Given this list of marker genes DEFA3, CD4, DEFA1, PRSS2 (serine protease 2), ART1 (ADP-ribosyltransferase 1), DEFA6, env, DEFA4, DEFA5, PRSS3, here is a description of the gene set: Humans have 7 alpha defensin genes plus 5 pseudogenes (see HGNC at http://www.genenames.org/genefamilies/DEFA). Alpha-defensins have six cysteines linked 1-6, 2-4, 3-5. The canonical sequence of alpha-defensins in humans is x1-2CXCRx2-3Cx3Ex3GxCx3Gx5CCx1-4, where x represents any amino acid residue. <br>Human alpha-defensins 1-4 are often called human neutrophil peptides (HNP1-4) as they were initially identified in neutrophil primary (azurophilic) granules. Alpha-defensins 5 and 6 (HD5, HD6) are products of Paneth cells. HNP-1 and -3 peptides are 30 residues long, differing only in the first amino acid. They are encoded by the genes DEFA1 and DEFA3 respectively. These exhibit copy number polymorphism, with some individuals having 4-14 copies per diploid genome, while 10-37% of individuals have no copies of DEFA3. HNP-4, encoded by DEFA4, is 33 amino acids long of which 22 differ from the other HNPs. It is a minor component of neutrophil granules compared to HNP1-3. In contrast to DEFA1 and DEFA3, the genes for HNP-4, HD-5 and HD-6 are only found as two copies per diploid genome (Linzmeier & Ganz 2005). HNP-2 is 29 amino acids in length and is the proteolytic product of cleavage of the N-terminal amino acid from either HNP-1 and/or HNP-3. part of: Defensins species: Homo sapiens Reactome Pathway: Alpha-defensins